The following is a description of a gene set: Shigella FimA to crosstalk between extrinsic and intrinsic apoptotic pathways. Pathway ID: N00950. Pathway type: Pathogen. Pathway class: nt06524 Apoptosis. Pathway Definition from KEGG: FimA -> VDAC1 == HK -| BAX Human Gene Set: KEGG_MEDICUS_PATHOGEN_SHIGELLA_FIMA_TO_CROSSTALK_BETWEEN_EXTRINSIC_AND_INTRINSIC_APOPTOTIC_PATHWAYS studied in species Homo sapiens, and this is the list of marker genes: HKDC1, HK2, VDAC1, HK1, HK3, BAX